Given this list of marker genes PGM1 (phosphoglucomutase 1), GALT, GALK1, GALE, GALM, AKR1B1, here is a description of the gene set: Reactome Pathway: Galactose catabolism part of: Metabolism of carbohydrates and carbohydrate derivatives studied in species Homo sapiens The main sources of galactose in the human diet are milk and milk products. The disaccharide lactose from these sources is hydrolyzed in the intestine to its constituent monosaccharides, glucose and galactose. Galactose is metabolized primarily in the liver in a sequence of three reactions that yield one molecule of glucose 1-phosphate per molecule of galactose. First, it is phosphorylated to yield galactose 1-phosphate. Then, galactose 1-phosphate and UDP-glucose react to form UDP-galactose and glucose 1-phosphate, and UDP-galactose undergoes epimerization to form UDP-glucose. In a reaction shared with other pathways, glucose 1-phosphate can be converted into glucose 6-phosphate.